The following is a description of a gene set: species: Homo sapiens Human Gene Set: GOBP_ORGANOPHOSPHATE_BIOSYNTHETIC_PROCESS The chemical reactions and pathways resulting in the biosynthesis of deoxyribose phosphate, the phosphorylated sugar 2-deoxy-erythro-pentose., and this is the list of marker genes: CKM, PIP5KL1, PPIP5K2, UQCC3, LIPA, GK2, HTR2C, PDHX, ABCA8, NDUFA12, LIPI, NPPB, DHODH, SRD5A3, ATP5PB, NDUFC2, FADS1, STOML2, NDUFB1, SLC4A7, PIGT, ATP6V0C, PIK3C3, ALOX15, CKMT1A, DCTD, MT-ND4, NME9, STAT3, GK5, NADSYN1, CLN3, NUS1, SPTLC1, SLC35C1, MPPE1, AGPAT1, AK1, TTC7A, AK6, IDO2 (NCBI Gene Id 169355), SELENOI, LPGAT1, MTMR3, PIPSL, CRLS1, MBOAT1, TAFAZZIN, CKMT2, RAB38, NDUFB8, DGKH, PIGW, GUCY2D, MIR675, FDPS, SERAC1, GMDS, IP6K3, LPCAT3, PLA2G4C, UPP1, GUCY1A2, ACSL5, NPPA, PIK3R4, GMPPA, IL4, THTPA, ELOVL7, PRPS2, ATP5MC1, MMUT, CMPK2, ADCY1, TGFB1, UAP1, NADK, DOLPP1, CTPS1, DUT, NDUFV2, FASN, ELOVL2, ACSF3, PIP4K2C, PIGC, GFUS, MLYCD, ADCY3, ORMDL1, RRM2, PI4KAP2, CMPK1, PIK3R1, NDUFB9, AK9, PIGZ, GPHN, GUK1, MTMR7, NR1H4, EFR3A, ATPSCKMT, GPAT4, DPM1, DPM2 (NCBI Gene Id 8818), ACACA, IP6K1, SLC27A2, DTYMK, NDUFA8, MVK, SDHD, MTMR1, TBPL1, GCDH, AK8, NDUFB10, ABCA2, SHMT1, NDUFS8, ADCY6, HACD1, NANS, NADK2, PIK3R3, PARP1, DHDDS, TREM2, PGM3, HTD2, CHKA, MVD, SACM1L, ATP5F1E, PNP, PAPSS1, ALDOA, PIP4K2B, NME3, PIGL, SLC44A1, NDUFA7, CKMT1B, SERINC1, UCKL1, FITM2, APOA2, TK2 (thymidine kinase 2), CRYL1, COX11, HTR2A, AGPAT2, GFPT2, LHCGR, APOA1, PDK3, AMPD2, INPP4A, GNE, ACP6, UAP1L1, NDUFB11, LPCAT1, ATP5MC3, PIKFYVE, PDHA1, MTHFD1, PNPLA3, NDUFC1, ACSS1, DGKD, PIGY, MTM1 (NCBI Gene Id 4534), DNAJC30, SAMD8, SH3YL1, ATP5MJ, NPR2, ELOVL3, PANK3, TPTE2, PLA2G4A, ACACB, GNPNAT1, IP6K2, CHP1, ADCY5, ABHD4, PLEK, XYLB, PANK2, PTH1R (NCBI Gene Id 5745), UGP2, FUOM, ACOT7, DPM3, GFPT1, MPI (mannose phosphate isomerase), NMRK2 (NCBI Gene Id 27231), ATP5MGL, GNPDA2 (glucosamine-6-phosphate deaminase 2), ADSS1, SLC44A3, MTMR14, SLC44A5, ELOVL6, CMAS, HYCC2, ATP5F1B (ATP synthase F1 subunit beta), AK5, PAICS, SLC25A10, PI4K2B, GPER1, AK2, PEMT, IDI2, AMDHD2, GPAA1, IDH1, NDUFA11, APRT, CKB, AKR1A1, PIK3C2A, HACD2, PITPNM3, DGKA, G6PD, SDHB, COASY, FABP3 (NCBI Gene Id 337956), DGKB, PCK1, PDXK, SPTLC2, NDUFA6, RFK, MTHFD2L, IPMK, NAMPT (NCBI Gene Id 10135), FLVCR1, NUDT2, AGPAT5, PGAP4, ISYNA1, ITPKB (NCBI Gene Id 3707), CPS1, NDUFB2, GART, ATP5F1C, NDUFA1, UGDH (UDP-glucose 6-dehydrogenase), ADCY7, FABP5, KYNU, MBOAT7 (NCBI Gene Id 79143), INPP5F, PFAS (NCBI Gene Id 5198), SGMS2, PRPSAP2, OCRL, AK3, PRKAG2, TMSB4X, SLC52A3, MOCOS, PDGFB, UXS1, BCKDK, ADCYAP1R1, PDHA2, IMPA1, PTDSS2, NMRK1, PRPS1, MT-ND1, GUCY1B1, HK1, NDUFS1, PIGQ, SLC44A2, GK (NCBI Gene Id 2710), ATG14, FITM1, DCAKD, LCAT, SLC19A2, ITPKA, SDHA, ADCY2, PIGO, MPC2, PIP4K2A, LETMD1, MTMR4, NME4, SH3GLB1, TECR, ATP5MK, MAP2K1, ENO1, SLC19A3, AVPR1B, ELOVL1, SYNJ2, PIGV, QPRT, RD3, PIGA (phosphatidylinositol glycan anchor biosynthesis class A), ADGRF5, ATM (ATM serine/threonine kinase), DGKI, ELOVL4, PIK3C2G, AMPD1, PPAT, ACLY, PI4K2A, NDUFA5, PLD1, PIK3C2B, TPK1, INPP1, CAD, FPGT, ADCY4, PIGM, MOCS3 (molybdenum cofactor synthesis 3), NANP, LIPH, PANK4, GUCY2F, ATP5PO, PRPS1L1, PPIP5K1, NDUFS4, PIGK, UVRAG, ADA, SERINC5, HSD17B12, PITPNM2, NDUFA9, AJUBA, PDHB, INPP5D, ATP5F1A, SLC30A5, LPCAT2, PLCG2, GMPPB, UPRT, PTH, SPHK2, GMPS, MTMR2 (NCBI Gene Id 8898), MFSD2A, SDHC, EFR3B, PIGP, SLC35A1, AGPAT3, MBOAT2, ADCY9, INPP5J, BPNT2 (NCBI Gene Id 54928), IDO1, INPP4B, ATP5MG (ATP synthase membrane subunit g), LDHC, PIGX, PMM2, PLAAT3, MTMR6, PRPSAP1, ADK, CEPT1, UPP2, ACSS2, PCYT2, NDUFS6, BMX, UMPS, PNPO, DGKG, NDUFB7, AGPAT4, GUCA1A, PCYT1A, NDUFB6, AK4 (adenylate kinase 4), NDUFB5, NME1, NMNAT3, FAR1, ATP5ME, NDUFS3, PGS1, DLAT, P2RY6, PGAP2, NPPC (natriuretic peptide C), VAC14, AK7, NME5, ACMSD, ADCY8, NDUFA13 (NCBI Gene Id 619501), PTDSS1, TMEM150A, CD244 (NCBI Gene Id 51744), PANK1, ETNK2 (ethanolamine kinase 2), ATP5F1EP2, FIG4, PTAFR, PIGU, ACSBG2, ATP5MF, NDUFB3, INPP5K, ATP5PF, DIP2A, MT-ND6, MT-ND3, PDK4, PAPSS2, XBP1, P2RY1, RRM2B (NCBI Gene Id 50484), NME7, PDK2, GUCY2C (guanylate cyclase 2C), HMGCS1, MOCS2, HDHD5, CDS2, GGPS1, PIK3CD, PIK3CG, ACSL4, PGAP3, ORMDL3, HPRT1, DGKQ, HTR2B, ABHD5, TPI1, HEXB, PPT2, ACSBG1, PIK3CB, LPCAT4, SORD, GPAT3, PIP5K1B, SLC25A13, VCP, PID1, NDUFB4, DOLK, CBR4, TMEM38B, CHAT, PIGS, NMNAT1 (NCBI Gene Id 64802), IDI1, ADSL, NTSR1, SLC25A19, OSBP, ACSL1, PTEN, KMO, FLAD1 (flavin adenine dinucleotide synthetase 1), NDUFA3, MIR30C1, UCK2, PIGN (NCBI Gene Id 23556), GNPAT, NDUFAB1 (NADH:ubiquinone oxidoreductase subunit AB1), ATP5PD, PPCDC, GPAT2, VPS9D1, VAPA, PIP5K1A, HMGCS2, NDUFS5, PIGF, PMVK, DGKZ, NDUFS7, PTPRQ, ETNK1, PLD2, IDH2, PRKG1, PINK1, PI4KB, CHPT1, GUCY1A1, TK1, MT-ATP6, SGMS1, CHKB, PITPNM1, RRM1, DGKK, IMPDH2, PPARA, NMNAT2, GARS1, NAPRT, CDIPT, PIGB, PDGFA, PPARD, NDUFS2, GNPDA1, MT-ND2, PCYT1B, PI4KA, PISD, NDUFA10, CTPS2, FAM3A, SCP2, GUCA1ANB-GUCA1A, ANTKMT, SMG1, SLC44A4, ASPDH, ABHD3, CAPN2, NFS1, CDS1, PMM1, MT-ND5, IPPK, TTC7B, MOCS1, SERINC4, ACAT1, HYCC1, IMPDH1 (inosine monophosphate dehydrogenase 1), IMPA2, ABHD8, NME2, SNCA, SYNJ1, NPR1, HAAO, CDA, PIP5K1C, DMAC2L, KARS1, INPP5E, LCLAT1, PRKN, DCK, PTPMT1, NDUFV1, PIK3CA, PPT1, TYMS, PDK1, PIGH, ME1, FCSK, ENTPD8, DGUOK, TAMM41, NME2P1, ADCY10, ACSL6 (acyl-CoA synthetase long chain family member 6), ITPKC, UCK1 (NCBI Gene Id 83549), ATP5IF1, LPIN1, PGK1, CWH43, NME6, BPNT1, BECN1, GPAM, AFMID, AMPD3, DLD, PGAP1, DGKE (diacylglycerol kinase epsilon), MT-ND4L, PPCS, ACSL3, INPPL1, ADSS2, ATIC, PLSCR1, NDUFA2, NAGK, PIGG, MT-ATP8, NDUFV3, ATP5F1D, DCXR, ATP5MC2, ELOVL5, TKT